The following is a description of a gene set: from publication Toker A, Engelbert D, Garg G, Polansky JK, Floess S, Miyao T, Baron U, Düber S, Geffers R, Giehr P, Schallenberg S, Kretschmer K, Olek S, Walter J, Weiss S, Hori S, Hamann A, Huehn J (PMID 23420886) Human Gene Set: GSE42021_TREG_VS_TCONV_PLN_UP studied in species Homo sapiens We investigated at which stage of maturation commitment to a stable Foxp3-expressing phenotype takes place. We assessed stability of Foxp3 expression in thymic Foxp3+ Treg subsets of different maturity, defined by CD24 expression. Next we compared gene expression profiles of Foxp3+ Treg subsets (+) of different maturity (24lo, 24int, 24hi) and could identify a set of genes that were specifically up or downregulated in Foxp3+ Tregs, but not in Foxp3- conventional T cells, in a maturation-dependent manner. Genes up-regulated in cells from peripheral lymph nodes: T reg versus T conv., and this is the list of marker genes: GTF2B, RPS6KC1, APOL6, IFI44, SLC25A28 (NCBI Gene Id 81894), CLEC2B, HERC6, DOCK4, THEMIS2, IGFLR1, TAP1, MX2, SAMD9, OAS3, ATF3, TAPBP, SECTM1, HLA-B, RRAGC, LAMP3, NRDC, PSMB10, RBCK1, TLR3, APOL1, SPATS2L, ID4, TOP1, PHF11, MSRB1, IFI30, MYD88 (MYD88 innate immune signal transduction adaptor, NCBI Gene Id 4615), DDX60, C1S, OAS1, IL15, GBP2, UBE2D1, TRIM22, IFIT3, PMAIP1, B2M, CTSS, RPS6KA5, CXCL10, TRIM38, RNF114, DRAM1 (DNA damage regulated autophagy modulator 1), IRF9, PSME2, HLA-E, VPS9D1, CCKAR, CASP7, IDO1, ZNF277, CEBPD, FAS, APOL3, OPTN, CALCOCO2, NREP, GALNT12, GTPBP1 (NCBI Gene Id 9567), IFIH1, PANX1, ZRSR2, BST2, TAP2, ADAR, ZNF410, RIGI, SERPING1, CFB, TASOR2, RTP4, CXCL5, IRF1, CDC42EP4, PSMB9, HLA-J, WARS1, CD47, CXCL11, PSMA4, BTN3A3, SAMHD1, NMI, NAPA, RASGRP3, TRANK1, IFIT5, PARP12, CXCL2, CBR3, DCP1A, IFI35, VRK2, TYMP, ISG15, HLA-C, TRIM21, IFITM3, PLSCR4, FERRY3, PLAUR, TRIM5, IFI27, FMR1, LAP3, IFIT2, SHFL, IL22RA1, CTSL, TRAFD1, C1R, LDLR (low density lipoprotein receptor), LGALS3BP (galectin 3 binding protein), USP33, JAK2, WSB1, STAT2, PLSCR1, SOCS1, RAB27A, HK1, ZNF107, XAF1, ADAMTSL3, APOL2, BCL2L13, CEACAM1, EHD4, PCLO, USP15, HERC5, NOD1, TDRD7, NBN, IFIT1, USP18, IRF7, HLA-A (major histocompatibility complex, class I, A), MSX1, HLA-F, ISG20, HEG1, OSMR, STAT3, CREM, IFI16, FAM111A, SP140L, IFITM1, TLK2, EIF2AK2, STAT1, OAS2, IRF8, UBE2L6, LARS2, PRKD2, RSAD2 (NCBI Gene Id 91543), TNFSF10, PML, NXT2, TRIM14, NFE2L3, SCN1A, RNF19B, BMPR2, FOSL2, OASL, TMEM140, C5orf15, LMO2, PLAAT4, CFH (NCBI Gene Id 3076), MAFF, CCL2, MAX, CSF1, IL10RB, GBP1, NKX3-1, JADE2, OGFR, PSMB8, LSM6, IFITM2, BATF3, CCDC68, IL12A, GSTK1, SP100, SLC12A7, SQOR, IFI44L, MX1, SP110